The following is a description of a gene set: Human Gene Set: ATGCTGG_MIR338 studied in species Homo sapiens Genes having at least one occurence of the motif ATGCTGG in their 3' untranslated region. The motif represents putative target (that is, seed match) of human mature miRNA hsa-miR-338 (v7.1 miRBase)., and this is the list of marker genes: LINS1, UNC45B, BCL9, TMEM255A, TANC1, NDUFAF5, ZNF335, SEC31B, SEMA6A, SLC9A9, GLS2, CCL21, GGA1, MAF, VAMP2, DMRT2, SEPTIN4, MORF4L2 (NCBI Gene Id 9643), FRY, VASP (vasodilator stimulated phosphoprotein), ZDHHC18, N4BP2L1, CCND1, MYCBP2, RUNX2 (RUNX family transcription factor 2), ADAM17 (NCBI Gene Id 6868), SKIDA1, FBXW7, SUGP1, SLK, ATP2B1, ARGLU1, ZNF579, TRIM33, KCND2, AP4E1, SLMAP, TSR1 (NCBI Gene Id 55720), TBC1D15, TNRC6B, UNC45A, ACTR2, EIF4E3, ATG9A, RPS19, ZBTB18, MSL2, SEMA6D, CNP, KCNMA1, FKBP1A, ZBTB39, CCNT2, UBE2Q1, ZDHHC21, GREB1L (GREB1 like retinoic acid receptor coactivator), TAS1R1, SRGAP3, DYRK2, RBM45, AMFR, CPEB3, MTG1, PVALB, WSB1, HMOX2, ZBTB10, ZNF607, GABPB2, CHTOP, ABCA12, SRSF2, NOVA1, SPTSSB, NRP1, YBX3, FBXO33, TRAF7, FAM120A, TBC1D8, LARP4, ZC3H7A (NCBI Gene Id 54895), SRSF8, SYN2, MYCN, NHS, MAP3K3, BNIP5, SECISBP2L, NRL, ESYT2, MAFB, SETD2, ACVR1, DUOX1, CBFB, SMTN, SGTB, FGF9, NUFIP2, SP6, RGS7BP, ARHGEF10L, SYT8, MORF4L1, ZFHX4, ARNT, CC2D2B, ETS1, PPP4R1, CLASP2, MAP4K3, PLD3, MACROD2